The following is a description of a gene set: Human Gene Set: MIR6717_5P Genes predicted to be targets of miRBase v22 microRNA hsa-miR-6717-5p in miRDB v6.0 with MirTarget v4 prediction scores > 80 (high confidence targets). species: Homo sapiens from publication Chen Y, Wang X (PMID 31504780), and this is the list of marker genes: NKD1, RS1 (retinoschisin 1), FKBP7, POLDIP3, ADAMTS14